Given this list of marker genes POLE4, POLE2, POLD1, RFC1, POLD3, MLH1, RPA3, RPA2, LIG1, MSH2, RFC4, EXO1, RFC2, MSH6, RPA1, POLE3, PMS2, RFC3, POLD2, RFC5, POLE, POLD4, PCNA, here is a description of the gene set: studied in species Homo sapiens Human Gene Set: WP_DNA_MISMATCH_REPAIR DNA mismatch repair